Given this list of marker genes TTC32, DEPDC1B, MRPS26, RAB32, DPH5, CTSF, DPP8, PIK3CG, SVIL, FHL2, PNO1, TJP2, CKS1B, MTAP, CRELD2, SLC29A1, NUCKS1, HGSNAT, ZFPM1, PAFAH2, ESYT1, C1orf131, ELOVL1, OAS3, IPCEF1 (interaction protein for cytohesin exchange factors 1), PDCD11, CDK5RAP3, BSCL2 (BSCL2 lipid droplet biogenesis associated, seipin), DTNBP1, C12orf75, APPL2, CST7 (cystatin F), ARAP3, LDAF1, NSUN2, SLC7A1, CFAP20DC, RGMB (NCBI Gene Id 285705), DIAPH2, TLE4, MCAT, BHLHE40, MED10, IL7R, DRG2, FOXRED2, PCYOX1, DPY19L1, SRM, CCR10 (NCBI Gene Id 51565), CNGA1, ATP6V1H, GYPC (glycophorin C (Gerbich blood group)), C1QBP, FAM167A, PSPC1, ARHGAP1, ECT2, SURF2, TRIM14, IL17RB, FRRS1, IFITM10 (NCBI Gene Id 402778), MCTP2, DNMT3B, INPP5B, RRP15, TTYH2, BOLA3, DLEU7, DTYMK, ADAM19, XRCC6, SSBP3, ARL4C, ICOS, PEX5, EIF4EBP2, CHST15, TTC27, ZDHHC18, ARL4D, ATP2A3, TRPM6, LITAF, TFB1M, GTF2IRD1, NOA1, ACAT1, ANGPTL4, AK7, CDKN2B, LRP8, CERS4, BZW2, FES, SLC25A10, TFAP4, DFFB, SETDB2, PLS1, HSPA5, METTL9, ISYNA1, PDLIM7, CRYBA1, VIPR1, MAFG, MCRIP2 (MAPK regulated corepressor interacting protein 2), PLEKHA8, MAF, ID2, SYTL3, TBCCD1, ZAP70 (zeta chain of T cell receptor associated protein kinase 70), POLR1B, RAP1A, SLC22A15, APOBR, SLC36A1, MGAT4B, TMEM126A, PXYLP1, FARP1, RFC5, MACROD1, URB2, MAPRE1, UBASH3B, RASSF5, MYO7A (myosin VIIA), GFOD2, MRPL3, SMCO4, EVI2B, CCR2, SCFD2, STMN1, TOR1AIP1, TYROBP, EVI2A, FAM174B, PARP12, CATSPERD, FAM78A, SPRY2, TRPV2, SLC38A1, COBLL1, SEPTIN11, MRPL19, FTSJ3, COMTD1, POU2AF1, LGALS1, CCDC126, GFM2, FASN, ADH1C, CRMP1, RRP12, RNF135, S100A6, SUSD1 (NCBI Gene Id 64420), MMD, GALR3, ATF6, RANBP1, LYN, ACVR1B (activin A receptor type 1B), LBR, DHX33, FXYD5, ATN1, TMED5, TTLL11, RAB31, MAN2A2, ANKRD63, GAR1, OAS2, SGSH, ACTR2, ALG2, MCM5, WDR12, B4GALNT4, PLAC8, TSHZ3, SPIB, PXDC1, IFT27, NUP58, PPP2R1B, DGLUCY (NCBI Gene Id 80017), SLBP, XRCC3, MCOLN2, IL21, here is a description of the gene set: studied in species Homo sapiens Human Gene Set: GSE40277_EOS_AND_LEF1_TRANSDUCED_VS_CTRL_CD4_TCELL_DN The transcription factor FoxP3 partakes dominantly in the specification and function of FoxP3+ CD4+ T regulatory cells (Tregs), but is neither strictly necessary nor sufficient to determine the characteristic Treg transcriptional signature. Computational network inference and experimental testing assessed the contribution of several other transcription factors (TFs). Enforced expression of Helios or Xbp1 elicited specific signatures, but Eos, Irf4, Satb1, Lef1 and Gata1 elicited exactly the same outcome, synergizing with FoxP3 to activate most of the Treg signature, including key TFs, and enhancing FoxP3 occupancy at its genomic targets. Conversely, the Treg signature was robust to inactivation of any single cofactor. A redundant genetic switch thus locks-in the Treg phenotype, a model which accounts for several aspects of Treg physiology, differentiation and stability. Genes down-regulated in CD4 T conv: over-expressing IKZF4 and LEF1 versus control. from publication Fu W, Ergun A, Lu T, Hill JA, Haxhinasto S, Fassett MS, Gazit R, Adoro S, Glimcher L, Chan S, Kastner P, Rossi D, Collins JJ, Mathis D, Benoist C (PMID 22961053)